Given this list of marker genes NAA80, RNF31, PLSCR3, UTP3, GALT, DNAL4, GLYR1, STX5, ABCA7, STRIP1, GUCD1, MRPL30, LENG1, COTL1, LIPE, SNRNP70, SNAPC4, EGLN2, PPP2CB, RGL2, BCL7B, PITPNM2, POMT1, ATXN2L, NIPAL3, ACAP1, IER3IP1, LASP1, MAP4K2 (NCBI Gene Id 5871), TRABD, FCHO1, DDB1, LMNB1, FAM193B, CLCN7, RIN3, HMG20B, CORO1A, MLLT6, RHBDL1, NFKBIL1, TMEM39A, PRKCH, RALGPS1, PARP6, MEX3D, USP11, SLC25A28 (solute carrier family 25 member 28), MND1, C6orf136, DGKE, DDX39B, NCLN, MTA1, PDLIM2 (NCBI Gene Id 64236), SIRT2, WHAMM, CCDC97, FGFR1OP2, LCP1, DLST, MBP, PIK3R4, FLOT1, THBS3, MIIP, OCEL1, MDM2, ABCD1, ERP29, COP1 (COP1 E3 ubiquitin ligase), CPT2, PELO, RNF19B, ZNF384, SLC5A6, MAFF, RAB5C, PRRC1, AKT1S1, PQBP1, LRP10, TOMM34, KANSL3, ZFAND2B, CACNB3 (NCBI Gene Id 784), NUP188 (NCBI Gene Id 23511), MAP3K11, MAPK8IP3, PPP2R3A, AP2B1, CPSF7, BFAR, XRCC1, RFX1 (regulatory factor X1), TMEM259, EDEM1, ZBTB48, BORCS6, TIFA, LMF2, AUP1, KAZALD1, NELFB, MORN2, TLN1, TBC1D9B, MOB3A, KATNA1, AP3D1, NRDC, ABI3, POLRMT, FEZF2, CTSA, MAGI1, RAF1, MRTFA, EYA3, HCLS1, UBE2D2, NFRKB, RNPEP, ARID1A, PTCD1, RPS6KB2, FAM216A, PACSIN1, CYTH1, GNB2, ADAMTS10 (NCBI Gene Id 81794), ACP3, AUH, SUSD6, DENND4B, HDAC7, MRPS35, ZNF653, COQ8B, ALDH2, IL27RA, DGAT1, UBE2Q1, CHD4, CDS2, ERGIC1, NEIL1, WBP1, PPP1R37, LMAN2L, RAPGEF3, SHF, SH2B1, PCYT2, RAB35, THY1, PRKAB2, CAPZB, IFFO1, TESK1 (NCBI Gene Id 7016), UBE4B, ANKRD54, FGF8, NPM3, ANKS1A, WASHC1, FAM20A, PHRF1, STRN4, TSC22D4, STX4, KLHL36, KANK3, DCLK2, CIZ1, LRSAM1, AGER, GSE1, TRIM11, FHOD1, UBA7, GLA, JOSD2, ABCB9, ADIPOR1, TBX6, TUFM, TFIP11, FASTK, CHRNB1, PPP1R12C, ZNF777, CENPT, ABHD8, VAPB, GPS2 (NCBI Gene Id 2874), RPS6KA4, PIK3R5, TATDN2, UCKL1, here is a description of the gene set: Genes down-regulated in monocytes (12h) versus macrophages (12h) treated with IL4. studied in species Homo sapiens Human Gene Set: GSE16385_MONOCYTE_VS_12H_IL4_TREATED_MACROPHAGE_DN Human CD14 positive monocytes were purified from healthy volunteers’ blood and cultured in vitro for 4, 12, 24, 72 hours. While culturing, macrophages were activated alternatively with interleukin-4 (IL-4 100 ng/ml) or classically with interferon-gamma (IFNg 100 ng/ml)+tumor necrosis factor (TNF 50 ng/ml) or left without activation. Simultaneously, macrophages were also treated with vehicle (DMSO:ethanol) or 1mM synthetic PPARg agonist, Rosiglitazone. We used Affymetrix microarrays (U133Plus 2.0) to analyze activation and PPARg-induced gene expression changes. from publication Szanto A, Balint BL, Nagy ZS, Barta E, Dezso B, Pap A, Szeles L, Poliska S, Oros M, Evans RM, Barak Y, Schwabe J, Nagy L (PMID 21093321)